The following is a description of a gene set: Genes down-regulated in macrophages stimulated by IFNG for 3h: control versus primed by IFNG. from publication Hu X, Park-Min KH, Ho HH, Ivashkiv LB (PMID 16148108) IFN-gamma transcriptional responses in control and IFN-gamma primed primary human macrophages studied in species Homo sapiens Human Gene Set: GSE1925_CTRL_VS_IFNG_PRIMED_MACROPHAGE_3H_IFNG_STIM_DN, and this is the list of marker genes: ST3GAL5, SERINC3, QRFPR, ENTPD1, RBM47, WNT2B, DCAKD, PIK3AP1, RNY3, PAPLN, SMAD6, EDIL3, H4C3, SSPN, OGDHL, ENTPD3, RYBP, KCNA7, PTAR1, JDP2, HRH3, PNPLA1, NUDT2, CACNG3, NKX2-2, CSRP2, RCC1, IDO2, PCGF2, TRAT1, SEBOX, MYH4, AVP, MEF2A, TMEM39B, ZBTB46, ANGPT1, ALDH2, SLC2A4, CFAP45, KCNJ8, PDILT, RBM46, YAP1, DOCK1, CCDC69, ARHGAP44, EPHA8, CACNA1F, PRKAR1B, AKAP7, SGPP2, CTCFL, GZMB, KCNK4, UNC45B, P2RY4, MASP1, GLI1, SH3BP1, APOH, GYS2, LCE1C, PODXL2 (podocalyxin like 2), DNM3, GPC6, EDA2R, SLC45A2, ADAMTSL2, USH2A, MIR495, P3H3, ITPKA, GZMA, EDARADD, SPINT3 (serine peptidase inhibitor, Kunitz type 3), CAPN6, MIR216B, WFDC12, CBX4, MGAM, LRATD1, KRTAP6-1, WNT10B, MEIS3, SLC43A1, EVC, GULOP, SLC25A48, SLC16A9, LAMC1, IGSF10, VIP, CISD2, C2, WNT3, CRCT1, MYOT, NKX2-3, RASD1, EFNA1, MIGA2, CCDC9, KRT6B, IDI2, RUNDC3A, XKR4, NR1H3, STXBP4 (NCBI Gene Id 337994), HES3, SPATA18, EPX, CCDC126, PHACTR3, AMT, NHLRC1, HPS1, SORBS1, C1QB, CLSTN2, SCN5A (sodium voltage-gated channel alpha subunit 5), NLGN3, OSMR, MYCL, PCNX2, IL12RB2, SYPL1, EPHB4